Given this list of marker genes SUN2, SUN1, SYNE2, SRGAP2, SRGAP2C, here is a description of the gene set: Human Gene Set: GOBP_MODULATION_OF_MICROTUBULE_CYTOSKELETON_INVOLVED_IN_CEREBRAL_CORTEX_RADIAL_GLIA_GUIDED_MIGRATION Rearrangements of the microtubule cytoskeleton that contribute to the movement of cells along radial glial cells as a component of the process of cerebral cortex glial-mediated radial migration. species: Homo sapiens